The following is a description of a gene set: studied in species Homo sapiens The membrane portion of the presynaptic active zone; it is the site where docking and fusion of synaptic vesicles occurs for the release of neurotransmitters. Human Gene Set: GOCC_PRESYNAPTIC_ACTIVE_ZONE_MEMBRANE, and this is the list of marker genes: NAPA, KCTD8, STX1A, SYT11, CACNA2D3, ATP2B4 (ATPase plasma membrane Ca2+ transporting 4), STX11, NTNG1, KCNJ8, STX19, ITGA3, GPM6A, CDH10, P2RY1, CACNA2D2, STX2, RYK, CPLX3, HCN1, P2RX1, GRIA1, LRFN3, NTNG2, NECTIN1, LPAR2, FZD3, GABRB1, ADRA2A, STX1B, GRIN2D, APBA1, CACNA2D1